Given this list of marker genes HTR1E (5-hydroxytryptamine receptor 1E), CACNA1C, PYGL, NDUFS7, FARP1, ZNF629, HSPB2, SEPTIN11, INPP4B, HNRNPR, PYGM, MRAS, GATD3, RASGRP2, SPN, TOR1AIP1, BAG5, PMS2P3, MAGEA4, COX7B, NDUFB8, HS2ST1, NFATC3, AFG3L2, IL5, TBCB, ESR1, NREP, MTIF2, ANGPTL7 (NCBI Gene Id 149217), SKAP2, KAT6A, GLMN, DDX52, NPHP4, MRPS12 (mitochondrial ribosomal protein S12), NDUFV1-DT, PI4K2A, OTUB1, ATRN, PCDHGA8, KCTD2, C2orf72, PPIC, CHAF1A, PMPCB, CELF1, MARK3, PRRG1, COQ2, RPS6KA1, HDAC6, OVOL3, PSME4, CELF2 (NCBI Gene Id 10659), ACP1, SPINK4, ORC1, PXDC1, TCF25, DNPH1, TAFAZZIN, MLLT1, ASMTL, PGAM2, MRPL58, ATP6V0D1, EIF2S3, USP10, DRG1, ANKRD17, MAPKAPK5-AS1, DLEC1, DNPEP, SET, ITPA, MDN1, UPF1, CDK6, DCTD, ADGRF5, SETD1B, ITGAL, GTF3C1, NDUFV1, MUC6, ARHGEF1, SHMT2, DHX16, ERCC1, WDR7, PRG2, RETREG3, IQSEC2, AATF, NBL1, IRF5, NR2C1, PYROXD1, KIAA0513, AMELX, CHD4, RAE1, LANCL1, TOMM40, NEUROD2, MED8, JADE2, GFUS, CPNE1, KLHL9, RAB14, COPS3, TUBB2A, PLCG2, ATP5MC1, CYFIP2 (NCBI Gene Id 81032), MBTPS1, GTF3C2, ATP11A, TRAPPC12, TRIM44, RASSF1, ARHGAP45, SHOC2, ARR3, PTPN22, CYC1, PRCP, MYD88, FBXW11, LSM4, SLC6A9, AP2S1, FEZ1, EPS15, NEMF, PADI2 (NCBI Gene Id 11240), CFD, PCMT1, PBX2, IMPDH1, VPS52, TTLL3, GPR15, COX5A, RAB4B, PSMA7, IFT25, NUDT3, RBCK1, RAMP3, PDCD10, FAM131A, TRANK1, SREBF2, DPYSL2, APOBEC3C, MPHOSPH10, SNRPD3, POP4, RTCA, PRRC2A (proline rich coiled-coil 2A), SART1, CPVL, TFDP2, NKX2-8, MFN2, CRYBB1, CDKN1B, ARID3A, ZNF134, SLC25A4, PPP2CB, DFFA, PCK2, SNRPE, GMPS, GAK, SLC4A3, STS, RIN2, NCOA6 (nuclear receptor coactivator 6), PRKACB, GNRH2, ZFC3H1, MAPRE1, LYRM9, GGA2, PMVK, CLSTN1, RPN2, FUT1, AMHR2, SH2B1, PWP1, PARP3 (NCBI Gene Id 25908), TRRAP, NFE2L1, here is a description of the gene set: studied in species Homo sapiens Genes down-regulated in comparison of macrophages exposed to L. major versus macrophages exposed to 5 worms/well B. malayi. Monocyte-derived dendritic cells (DC) and macrophages (MΦ) generated in vitro from the same individual blood donors were exposed to five different pathogens, and gene expression profiles were assessed by microarray analysis. Responses to Mycobacterium tuberculosis and to phylogenetically distinct protozoan (Leishmania major, L. donovani, Toxoplasma gondii) and helminth (Brugia malayi) parasites were examined, each of which produces chronic infections in humans yet vary considerably in the nature of the immune responses they trigger. from publication Chaussabel D, Semnani RT, McDowell MA, Sacks D, Sher A, Nutman TB (PMID 12663451) Human Gene Set: GSE360_L_MAJOR_VS_B_MALAYI_LOW_DOSE_MAC_DN